Given this list of marker genes Igf1r, Rest, Gfi1, Ffar3, Ppargc1a, Lhcgr, Dkk3, Cyp27b1, Cacna1a, Pde8b, Cyp17a1, Arnt, Bmp6 (bone morphogenetic protein 6), Nfkb1, Igf2, H6pd, Igf1, Dgkq, Por, Wnt4, Gh, Clcn2, Bmp2, Stc2, Hif1a, Dab2, Nr3c1, Atp1a1, Nr5a2, Egr1, Bmp5, here is a description of the gene set: Any process that modulates the frequency, rate or extent of the chemical reactions and pathways resulting in the formation of hormones. studied in species Mus musculus Mouse Gene Set: GOBP_REGULATION_OF_HORMONE_BIOSYNTHETIC_PROCESS